The following is a description of a gene set: part of: Pre-NOTCH Expression and Processing electronically inferred by orthology from the curated human pathway Reactome Pathway: Pre-NOTCH Processing in Golgi This event has been computationally inferred from an event that has been demonstrated in another species.<p>The inference is based on the homology mapping from PANTHER. Briefly, reactions for which all involved PhysicalEntities (in input, output and catalyst) have a mapped orthologue/paralogue (for complexes at least 75% of components must have a mapping) are inferred to the other species. studied in species Mus musculus, and this is the list of marker genes: Notch3 (NCBI Gene Id 18131, notch 3)